Given this list of marker genes Fah, Gstz1, Hgd, Tat, Hpd, here is a description of the gene set: Tyrosine catabolism Mouse Gene Set: REACTOME_TYROSINE_CATABOLISM species: Mus musculus